The following is a description of a gene set: The movement of a myeloid dendritic cell in response to an external stimulus. studied in species Mus musculus Mouse Gene Set: GOBP_MYELOID_DENDRITIC_CELL_CHEMOTAXIS, and this is the list of marker genes: Ccl21e, Ccl21b (NCBI Gene Id 20298), Ccl19-ps5, Ccl21d, Retnlg, Spi1, Ccl21a, Ccl19-ps6, Ccl19-ps1, Ccl21f (NCBI Gene Id 100504346), Ccl19-ps3, Ccl19-ps4, Arhgef5, Ccl19, Ccr7